The following is a description of a gene set: Binding to a component or product of the complement cascade. studied in species Homo sapiens Human Gene Set: GOMF_COMPLEMENT_BINDING, and this is the list of marker genes: MASP2, CFHR5, C8A (complement C8 alpha chain), CFHR4, CD93, CALR, C4B, CFB, PTX3, CR2, CFHR1, ITGAM, CRP, MEGF10, PHB1, CR1, CFH, CFHR2, VSIG4, CFHR3, C4A, APCS, ITGB2, C1QBP, CD59